Given this list of marker genes Rab5a (RAB5A, member RAS oncogene family), Kxd1, Borcs5, Borcs8, Pclo, Borcs7, Chmp3, Snapin, Borcs6, Als2, Bloc1s2, Bloc1s1, here is a description of the gene set: studied in species Mus musculus Any process that modulates the volume of an endosome, a membrane-bounded organelle that carries materials newly ingested by endocytosis. Mouse Gene Set: GOBP_REGULATION_OF_ENDOSOME_SIZE